Given this list of marker genes CUX2, ANKRD27, NUMBL, PAFAH1B1, CUX1, CAPRIN2, CDKL3 (cyclin dependent kinase like 3), SS18L1, GPRASP3, PRKDC, RELN, CDKL5, OBSL1, EPHA4, ARMCX5-GPRASP2, DBN1, LRP8, IL1RAPL1, CUL7, CAMK2B, TBC1D24, STAU2, CAPRIN1, FBXW8, SLC30A1, HDAC6, BAIAP2, RAB21, ITPKA, MPL, EEF2K, ANAPC2, DHX36 (DEAH-box helicase 36), EPHB2, FZD4, PARP6, PTPRD, here is a description of the gene set: Human Gene Set: GOBP_POSITIVE_REGULATION_OF_CELL_MORPHOGENESIS Any process that increases the frequency, rate or extent of cell morphogenesis contributing to cell differentiation. Cell morphogenesis involved in differentiation is the change in form (cell shape and size) that occurs when relatively unspecialized cells acquire specialized structural and/or functional features that characterize the cells, tissues, or organs of the mature organism or some other relatively stable phase of the organism's life history. species: Homo sapiens